Given this list of marker genes GRIK3, TIE1, EPHB1, GJC2, CNTFR, RAMP1, RYR1, KCNH2, GJB1, ADRB2, GPR65, CHRNB4, LILRA3, CLCN5, CHRNE (cholinergic receptor nicotinic epsilon subunit), KCNB2, IL3RA, PTPRO, P2RX3, PDGFRB, KCNK3, ADCYAP1R1, ITGB7, IL12RB2, AXL, KCNJ2 (potassium inwardly rectifying channel subfamily J member 2), KCNMB1, CHRNA7 (NCBI Gene Id 1139), KCNK5, KDR, GABRG2, TRPM2, CNGA1, PLA2R1, ASIC1, PDGFRA, CD86, ASGR2 (asialoglycoprotein receptor 2), TNFRSF11B, TNFRSF1B, GHR, AQP7, BMPR1B (NCBI Gene Id 658), KLRK1, MLC1, LIFR, ITGAX, KCNA4, KCNJ12, FCGR3A, GABRD, GABRA2, FCGR3B, TNFRSF21, NRP1, CD180, IL6ST, LILRB4, IL13RA1, ITGB5, ITGB2, FCGR1A, IL2RA (NCBI Gene Id 3559), FCER1A, HYAL2, CHRNA3, GRIK1, CNTNAP1, ASGR1, KCNK1, KDELR3, CD80, FCER2, ANPEP, TNFRSF10A, GFRA1, ITGA3, PTPRS, MRC1, EPHA7, IL4R, LRP1, CLCN2, CHRM1, SHROOM2 (shroom family member 2), FOLR2, GLRA2, MERTK, ITGA2B, GLRA3, CYBB, GPRC5A, KCNJ11, CD2, LILRB2, NPY2R, ITGA9, PTPRK, KLRC4, BTN1A1, FCGRT, IL13RA2, CSF3R, ERBB4, KCNA1, PTPRN, MAL, ITGB8, CSF2RA, PDGFRL, NTRK2, MST1R, KIR3DL1, P2RX7, PTPRF, KCNQ3, SCN2B, AQP9, TNFRSF4, GFRA3, FCGR2A, FOLR3, SCN7A, S1PR2, CRLF1, CHRNB1, SCNN1A, CSF2RB, FGFR1, CNGA3, KCNE1, TGFBR1, PRLR, SCN9A, FGFR2, KCNJ8, CLCNKB, IL2RG, AR, P2RX1, CHRNA2, FGFR3, ITPR2, FOLR1, PTPRM, FXYD2, SEMA4D, CHRNB3, GABRP, LILRA2, TACSTD2, ITGAL, PTPRN2, TNFRSF25, GPA33, GJB2, IL2RB, AQP4, NPR3, FXYD1, KCNA6, IL10RA, IFNGR1, ADGRE1, AQP6, KCNC4, UNC13B, TNFRSF13B, KCNN4, OLR1, CLCNKA, LRP2, KIR2DL3, ITGAM, FPR1, P2RY2, TEK, TNFSF11, TNFRSF17, CACNG1, HBEGF, GLRA1, ROS1, GABRR1, GLYAT, KIT, IL1R2 (interleukin 1 receptor type 2), IL7R, CLIC2, TGFBRAP1, GPRC5B, GJA5, EPHA2, IL6R, ERBB2, GFRA2, GPR75, EPHA4, KCNC3, PTK7 (protein tyrosine kinase 7 (inactive)), GABRG3, GRIN1, TGFBR3, FCAR, EPHB2, GJA1, DDR2, MS4A2, GABRB3, EPHB6, CHRNA4, here is a description of the gene set: Porins / transporters. species: Homo sapiens Human Gene Set: MODULE_63